Given this list of marker genes Gja5, Tgfb2, Sox4 (NCBI Gene Id 20677), Nsd2, Gata4, Acvr1, here is a description of the gene set: The progression of the septum primum over time, from its formation to the mature structure. Mouse Gene Set: GOBP_SEPTUM_PRIMUM_DEVELOPMENT species: Mus musculus